Given this list of marker genes ABHD2, ATP1B1, NHLRC2, TCF4, SLC25A20, VPS37B, COLGALT2, NPC1, TNFRSF1A (TNF receptor superfamily member 1A), ADCY2, NFAT5, TFIP11, GSN, NCR1, CREB3L2, ZNF432, TOX, GOLGA8H, GFOD1, HELZ, ZCCHC24, SMAD5, SNAP29, UBR2, ACTR8, TOR4A, PCNX4, SH3GLB1, HIRA, IGFBP7, ELF4, CFLAR, TARDBP, MCTP2, SETX, NLRX1, ITCH, MAP3K8, FEZ2, PREP, MEX3C, WDR41, S1PR5, PON2, CDK17, TM6SF1, CLTC, BCL2L2, PYHIN1, ZSWIM8, CYRIA, NOTCH1, MACF1, SLCO4C1, GIGYF2, RHOBTB3, CCDC47, S100A9, CEBPD, RMC1, RFTN1, PPM1B, RAC1, KIFAP3, YPEL1, SMURF2, KIR2DL4, CERS4, SART3, UBB, PSME4 (proteasome activator subunit 4), CTBP2, PI4K2A, LARP7, ATP10D, PISD, RTF1 (NCBI Gene Id 23168), PHF21A, TSPOAP1, PTPRC, G6PD, CHST12, TRIM58, IVNS1ABP, DCAF7, ATP10A, PTPRE, PHTF1, LTF, INPP1, FURIN, UEVLD, STBD1, TNPO1, CRIM1, TUT7, KIR3DS1, CCDC186, IFI16, NUP133 (NCBI Gene Id 55746), RHOQ, FRYL, CEP43, KIR2DL1, AOAH, DVL3, YIPF6, ZNF701, HEG1, SEC24C, UBE2W, PPP1R12A, SSH1, TBC1D31, TMEM87A, LAMP1, PCTP, RAB11FIP1, LAT2, CENPF, GALNT3, RNF115, YES1, SLFN12, BARD1, ATP6V1A, HTT (huntingtin), CLASP2, NEDD9, MTMR3, PRR14, STX7, IL18RAP, LCN2, HLA-C, PLEKHO2, ARIH1, SLC5A3, ARHGEF12, RNF146, PLCG2, MED20, DUSP22 (NCBI Gene Id 56940), JARID2, SH2D2A, B2M, ADAM8, S100A12, NARF, ZDHHC17, GMEB1, CD247, PIMREG, SUSD6, C2CD3, LDB2, NCOA2, IGF2R, ARHGEF3, TRIP4, ZFYVE16, TBL1X, CSNK1D, CLASP1, DHRS7B, KDM5A (NCBI Gene Id 5927), ZNF443, NME8, RSF1, TRIP12, PRR5L, HIPK2, CDYL, AKR1C3, WIPI1, DAB2, IL18R1, UVRAG, NCAM1, PRDM10, FAM13B, TMEM62, RAD23B, MON2, TIPRL, ATP8B4 (NCBI Gene Id 79895), RNF4 (ring finger protein 4), MCF2L2, PPP1R3D, SLA, ARAP2, INTS6, MTG1, NIPBL (NCBI Gene Id 25836), C5orf15, IST1, LYST, TACC1 (transforming acidic coiled-coil containing protein 1), here is a description of the gene set: from publication Abbas AR, Baldwin D, Ma Y, Ouyang W, Gurney A, Martin F, Fong S, van Lookeren Campagne M, Godowski P, Williams PM, Chan AC, Clark HF (PMID 15789058) Human Gene Set: GSE22886_NAIVE_TCELL_VS_NKCELL_DN species: Homo sapiens Genes down-regulated in comparison of naive CD4 CD8 T cells versus unstimulated NK cells. Immune cell-specific expression is one indication of the importance of a gene's role in the immune response. In order to identify such patterns, we set out to broadly profile gene expression in a variety of immune cells.